The following is a description of a gene set: Any process that activates or increases the frequency, rate or extent of the addition of SUMO groups to a protein. species: Mus musculus Mouse Gene Set: GOBP_POSITIVE_REGULATION_OF_PROTEIN_SUMOYLATION, and this is the list of marker genes: Mul1, Tollip, Rasd2, Ahrr, Pias3, Pias4, Sumo2, Traf7, Pias1 (protein inhibitor of activated STAT 1), Rwdd3, Sae1, Arnt, Hdac4, Uba2, Gnl3, Cdkn2a